The following is a description of a gene set: Human Gene Set: GOMF_SNRNA_BINDING Binding to a small nuclear RNA (snRNA). species: Homo sapiens, and this is the list of marker genes: PRPF4 (pre-mRNA splicing tri-snRNP complex factor PRPF4), SNRPA1, LARP7, EIF5A, RBMXL2, HNRNPU, RBM7, NCBP2, GEMIN5, RNU4-1, SNRPB2, LSM10, LSM8, RBM22, COIL, RNU6-1, DDX21, CELF3, TOE1, RO60, RNPC3, LSM3, RBMXL3, SF3B3, RNU6ATAC, C9orf78, CCNT2, LSM7, LSM2, EFTUD2, HEXIM1 (NCBI Gene Id 10614), RBM41, METTL16, PRPF8, SNU13, LSM11, RNU4ATAC, RNU6-7, SNRNP35, DDX39B, CCNT1, HEXIM2, ISG20, PRPF31, SART3, SNRPD3, LSM4, MEPCE, RNU4-2, SNRPA, CDK9, SNRNP70, TUT1, SNRPC, RNU6-9